The following is a description of a gene set: Increased vertical distance from the vermillion border of the lower lip to the inferior-most point of the chin. Human Gene Set: HP_TALL_CHIN Tall chin studied in species Homo sapiens, and this is the list of marker genes: EIF2S3, CHD8, TLK2, NSD1, APC2, MYH8, CRELD1, OPHN1